The following is a description of a gene set: studied in species Homo sapiens Human Gene Set: GOBP_RESPONSE_TO_XENOBIOTIC_STIMULUS Any process that results in a change in state or activity of a cell or an organism (in terms of movement, secretion, enzyme production, gene expression, etc.) as a result of a stimulus from a xenobiotic, a compound foreign to the organism exposed to it. It may be synthesized by another organism (like ampicilin) or it can be a synthetic chemical., and this is the list of marker genes: CCNT1 (cyclin T1), GSTM3, PMS2, AHRR (aryl hydrocarbon receptor repressor), GSTP1, CYBA, KCNE2, VAV3, SLC10A1, ADIPOQ, CYP2C19, ABCC4, XPC, LCK, PDE4B, ABCB1, SRR, ACTC1, MMP2 (matrix metallopeptidase 2), ERRFI1, CYP2R1, RPP21, FBP1, ABCC2, PRNP, THBS1, GAS6, AS3MT, GSTO2, MIR326, MIR508, RORA, SLC28A2, FOSL2, CHUK, GPR52, CES2, PPP1R12A, MIR133A1, CEBPA, CYP4F2, NKX6-1, RNF149, AIP, SRP68, NPPC, HSF1, SRD5A2, HDAC3, ASIC2, PRKAA1, TGFB1, PDE2A, HNF4A, RBP4 (retinol binding protein 4), SLC26A5, GRIN1, GAL, HSP90AA1, MIR34B, EI24, LTA, GSTM4, SNCA, PLIN2, ABCG8, TP53, UGT2B7, TP73, NAT2, LPO, CYP3A5, CALR, FZD1, CYP4F12, NFATC2, FECH, PRKCE, ROGDI, ACSM2B, RAD54B, GATA3, AOX1 (aldehyde oxidase 1), FMO1 (NCBI Gene Id 2326), STAT1, P2RX7, RAP2A, CYP2B6, MTHFR, ABCC6, TXNIP, CDK1, ADSS1, GSTM1, NQO1, CYP1A1, SMOX, PNP, TXNRD2, MT-ND1, PPM1F, SLCO1B3, OTC, AMELX, BRAF, CASP3, BLOC1S6, UGT1A7, NPC1, BECN1, SULT1A1, BAK1, NPFF, UGT2B11, GABRB3, GSTA3, SLC29A1 (solute carrier family 29 member 1 (Augustine blood group), NCBI Gene Id 220811), BLMH, MAP1B, ASS1, MMP7, AIM2, PDE3A, ADORA2A, KCNQ3, PTPRM, RAD51, UGT1A4, ABAT, FMO2, CSAG2, TNF, UGT1A6, BGLAP, EFTUD2, HTR2A (5-hydroxytryptamine receptor 2A), AGPAT2 (1-acylglycerol-3-phosphate O-acyltransferase 2), CYP2A13, UGT2B17, SLCO2B1 (solute carrier organic anion transporter family member 2B1), CRH, HTR2B, CYP2D6, AHR, RAP1A, SLC6A3, CRHBP, PTH, VAV1, SLC1A1, VEGFC, ATP1A1, COL18A1, TPMT, NOS2, SLC29A3, ABCC5, GCLM (NCBI Gene Id 2730), GSTA5, MDM2, CHEK2, TFAP2B, CYP1B1, TGIF1, HCN2, GPLD1, CTPS1, CCNB1, ABCC8, CYBB, SLC22A12, UGT2A2, PCNA, SLC28A3, SULT1C4, REN, CYP3A7, PFAS, STAT3, CES3, PTCH1, FMO4, IL1B, UGT1A1, CBR1, WNK4, AADAC, MIR378A, NUDT15, GSTA4, SUFU (SUFU negative regulator of hedgehog signaling), C1orf115, CYP2S1 (cytochrome P450 family 2 subfamily S member 1), ACACB, ADCYAP1R1 (ADCYAP receptor type I), CYP1A2, ABCA1, MYC, PRKN (parkin RBR E3 ubiquitin protein ligase), GSTM2 (glutathione S-transferase mu 2), FUT1, CYP2W1, GRIA1, RHBDD3, CDH1, CAT, HDAC2, OXCT1, COMT, SFRP1, NFE2L2, SLC1A3, PARP4, CYP2F1, CTNNB1, SEMA3C, MEF2C, NCKAP1L, TOP1, KCNK3, ACSL1 (acyl-CoA synthetase long chain family member 1), MIR1-1, CYP2A6, ALAS1, MIR9-1, ABCC3, GSTA1, VAV2, CBR3, FABP3, ACSM1, TERF1, CYP3A4, PDX1, NKX3-1, FZD3, SOD2, MCM7, ABCA3, UGT1A3, ABCB11, MIR130B, PDE4A, ABHD10 (NCBI Gene Id 55347), SULT1A2, E2F1, GPX1 (NCBI Gene Id 2876), GRM2, SLC12A5, PMS1, TRPA1, KCNQ1, RBM22, CRYZ, GRIN2A, CYP2E1, S100A12, HMGCS2, AKR1C1, BCL2, MT-CYB, UCHL1, CAD, PRICKLE1, AMH, LYN, BCAR3, PPM1E, HTR1B, MIR27B, BLOC1S3, SCNN1B, ALAD, MIR133B, GABRG3, RAB6C, SULT2A1 (sulfotransferase family 2A member 1), IL10, SLC19A1, MYO6, TRAF3IP2, DUSP6, XPO1, ABCC1, MIR186, CREB1, TBXA2R, DRD1, UGT2A1, ADA, ITGA3, ADAM17, JUN, FYN, SRD5A1, COL1A1, CCND1, HADH, CDK4, SLC22A1, CYP2C9 (NCBI Gene Id 1560), UGT2B15 (UDP glucuronosyltransferase family 2 member B15), KCNC1, CDH13, CYP2C18, BCHE, NFKBIZ, AOC2, UGT1A9, NTRK1, SREBF1, SCGB1A1, PON3, GSTA2, PPOX, PPP1R14A, SOX10, GLYAT, LCN2, PPP1R9B (protein phosphatase 1 regulatory subunit 9B), RPTOR, SLC22A7, FOS, ABCA2, UGT1A10, SLC34A1, TSPO (NCBI Gene Id 706), EEF2, RELA, MDK, RORC, SULT1A3, CARD9, SMPD1, RBBP9, ENO2, SLITRK5, CYP2J2, RB1, EMX1, CYP2C8, FGF8, CSAG3, ABL1, ADRA1A (NCBI Gene Id 148), UMOD, RAD54L, SPINK4 (NCBI Gene Id 27290), HSD11B2, DNMT3A, CYP26A1, CYP2A7, CRKL, TIGAR, DRD3, UGT2B4, DVL3, CYB5B, ITGB3, GATA6, COL6A1, KCNJ11, BPHL, GUK1, SULT1C3, FMO5 (NCBI Gene Id 2330), KCNJ8, FOXO3, ACER2, ALDH2, CPS1 (NCBI Gene Id 1373), FOSB, CPT1A, GNA12, LIPA, CD69, SLCO1A2, SST, GATA4, SLC6A4, UBE2B, CA9, ALDH3A1, POR, RECQL5, UGT2A3, TENT4A, GSTO1, LOX, ABCC9, EDN1, NOS1, MIR873, NPAS2, IGFBP2, ATG5, TFRC, EMX2, N6AMT1, GCLC, HSPG2, SMTNL1, MIR185, TGFBR2, CERS1, ITGA2, VKORC1, CYP2U1, ABCG5, SS18, PRKAA2, KCNH2, LRP8, MIR495, ATR, ANKRD1, MIR451A, MIR129-1 (microRNA 129-1), TLR3, OXSR1, ATP4A, CYP46A1, CMBL, SCN11A, ABCD3, ADD3, SULT1A4, UGT1A8, TP53I13, SOD1, SLC6A11, HDAC5, DRD2, SLC6A2, EPHX1, SFRP2 (NCBI Gene Id 6423), ACAA1, CENPF, NCEH1, SLC1A2, FKRP, NAT1, SULT1B1, SLCO1B1, CYP26B1, NR1I2, CD38